The following is a description of a gene set: species: Mus musculus Mouse Gene Set: RAMJAUN_APOPTOSIS_BY_TGFB1_VIA_MAPK1_UP Apoptotic genes dependent on MAPK1 and up-regulated in AML12 cells (hepatocytes) after stimulation with TGFB1. from publication Ramjaun AR, Tomlinson S, Eddaoudi A, Downward J (PMID 16909112) Transforming growth factor-beta (TGFbeta)-activated signalling pathways can lead to apoptosis, growth arrest or promotion of malignant behaviour, dependent on cellular context. The molecular mechanisms involved in TGFbeta-induced apoptosis remain controversial; although changes in gene expression are thought to be pivotal to the process, several different candidate apoptotic initiators and mediators have been proposed. Smad4, a critical component of the TGFbeta-induced transcriptional machinery, is shown here to be essential for induction of apoptosis. Gene expression analysis identified the proapoptotic Bcl-2 family members, Bmf and Bim, as induced by TGFbeta, dependent on both Smad4 and p38 function and the generation of reactive oxygen species. TGFbeta-induced Bmf and Bim localize to cellular membranes implicated in apoptosis. Inhibition of the TGFbeta-induced expression of both these proteins together provides significant protection of cells from apoptosis. The TGFbeta-triggered cell death programme thus involves induction of multiple BH3-only proteins during the induction of apoptosis., and this is the list of marker genes: Hspa1b, Bmf, Bcl2l11, Card10, Sh3glb1, Trp53inp1